Given this list of marker genes Gnas, Drd3, Nherf1, Gnai1, Nsf, Clic6, Cav2, Dnm1, Palm (NCBI Gene Id 18483), Dnm2, Gna13, Snx5, Dlg4, Ppp1r1b, Arrb2, Ptpn11, Vps35, Dnajc14, Ptger1, Ppp1r9b, Drd1, Grin2b, Gna12, Agtr1a (NCBI Gene Id 72294), Atp1a3, Grk3, here is a description of the gene set: studied in species Mus musculus Mouse Gene Set: GOMF_DOPAMINE_RECEPTOR_BINDING Binding to a dopamine receptor.